The following is a description of a gene set: Human Gene Set: chr9q33 species: Homo sapiens, and this is the list of marker genes: TUBB4BP6, NEK6, RN7SL30P, OR1N2, OR1J1, MIR7150, LOC124902337, ZBTB6, ARPC5L, GARNL3, C5, GGTA1, PTGS1 (NCBI Gene Id 5742), MIR181B2, TRAF1, FXNP2, SLC2A8, HMGB1P37, OR1L8, OR5C1, PIGFP2, HSPA5, TNFSF8, RN7SL181P, NR5A1, LHX6 (LIM homeobox 6), LHX2-AS1, B3GALT9, ZBTB26, NDUFA8, WDR38, RNU6-1082P, OR1B1, PSMD5, MEGF9, RN7SKP125, CRB2, GSN-AS1, MORN5, LHX2, LMX1B-DT, RNU6-1020P, BRINP1, AHCYP2, STRBP, MAPKAP1, LINC02578, RPL35, RNY1P15, LINC01613, OR1L4, PBX3, SNORA70C, DAB2IP, ZNF79, LMX1B, PBX3-DT, MRRF, ENSG00000309565, MIR601, GOLGA1, RNU4-82P, DENRP4, PPP6C, RABEPK, KRT18P67, MIR600, RBM18, OR1H1P, MIR181A2 (NCBI Gene Id 406954), RN7SL302P, TLR4, OR1N1, OR1K1, LINC00474, PAPPA-AS1, NR6A1, RPSAP76, PRPS1P2, GPR21, ENSG00000236461, RN7SKP128, ANGPTL2, PAPPA, CDK5RAP2, OLFML2A (olfactomedin like 2A), SKA2P1, ASTN2, OR1L1, RAB14, RALGPS1, NRON, RN7SL187P, SNORD90, HNRNPA1P15, RABGAP1, HSPA5-DT, ENSG00000297553, FBXW2, PDCL (phosducin like), ADGRD2, OR1J4, TTLL11, TRIM32, CUTALP, TLK1P1, RPL35AP22, GAPVD1, PHF19, OR1L6, RC3H2, GSN, ASTN2-AS1, ENSG00000230894, OR1L3, TNC, PAPPA-AS2, MIR181A2HG (MIR181A2 host gene), MIR147A, TPT1P9, MIR600HG, OR1J2, SNORA65, ZBTB43, PSMB7, ENSG00000233569, OR1Q1, CNTRL, RPL12 (ribosomal protein L12), ENSG00000301342, ENSG00000227355, RPL10P3, ENSG00000225050, LRSAM1, ENSG00000288537, ZBTB34, MIR4478, STOM, MVB12B, SCAI, DENND1A